The following is a description of a gene set: The chemical reactions and pathways resulting in the breakdown of a deoxyribonucleotide, a compound consisting of deoxyribonucleoside (a base linked to a deoxyribose sugar) esterified with a phosphate group at either the 3' or 5'-hydroxyl group of the sugar. studied in species Mus musculus Mouse Gene Set: GOBP_DEOXYRIBONUCLEOTIDE_CATABOLIC_PROCESS, and this is the list of marker genes: Nudt16, Samhd1, Urad, Nt5m, Tymp, Upp1, Ada (NCBI Gene Id 11486), Xdh, Dpyd, Dctpp1, Gda, Dnph1, Uox, Nudt18, Nt5c1a, Urah, Nt5c2, Upp2, Dpys, Nt5c3, Cda, Dera, Nudt15, Pnp, Upb1, Nt5c, Dut